The following is a description of a gene set: A protein complex that in its canonical form is composed of two identical immunoglobulin heavy chains and two identical immunoglobulin light chains, held together by disulfide bonds and sometimes complexed with additional proteins. An immunoglobulin complex may be embedded in the plasma membrane or present in the extracellular space, in mucosal areas or other tissues, or circulating in the blood or lymph. species: Mus musculus Mouse Gene Set: GOCC_IMMUNOGLOBULIN_COMPLEX, and this is the list of marker genes: Igkv12-44, Igkv14-111, Ighv3-5, Igkv7-33, Cd79a, Igkv9-120, Igkv8-30, Igkv4-90, Trav16d-dv11, Igkv3-4 (NCBI Gene Id 626347), Trdv2-2, Igkv4-72, Igkv4-53, Ighv1-61, Igkv10-96, Igkv5-45, Ighv1-62-3 (NCBI Gene Id 668549), Igkv8-26, Igkv3-2, Igkv8-28, Igkv4-61, Igkc, Ighm, Igkv3-5, Igkv6-20, Igkv8-19, Vpreb1a, Igkv5-39, Pigr, Iglc3, Igkv4-79, Cd79b, Igkv11-125, Trdv5, Igkv1-132, Jchain, Igkv13-84 (NCBI Gene Id 692152), Ighd, Trav16, Ighv1-72, Ighv1-84, Igkv6-14, Igkv4-92, Igkv17-121, Igkv10-95, Igkv2-112, Igkv6-32, Igkv4-74, Trdv4, Igkv3-7, Igkv3-1, Igha, Igkv5-48, Iglv1, Igkv4-57, Igkv1-131, Igll1, Igkv1-133, Igkv3-3, Igkv4-51, Igkv8-34, Igkv6-23, Igkv4-91, Ighg2c, Igkv2-137, Iglv3 (immunoglobulin lambda variable 3), Igkv15-103, Igkv1-122, Iglc4, Igkv8-27, Igkv4-80, Ighv2-4, Igkv2-109, Igkv4-50, Igkv4-69, Igkv4-81, Igkv4-58, Ighe, Igkv4-57-1, Igkv8-21, Igkv18-36 (immunoglobulin kappa chain variable 18-36), Igkv9-123, Igkv6-17, Ighg1, Igkv20-101-2, Syk, Igkv1-110, Igkv12-46, Iglc2, Iglc1, Igkv4-68, Igkv5-43, Ighg3, Igkv1-88, Ighg2b, Igkv16-104, Igkv8-24, Igkv4-78 (NCBI Gene Id 545849), Vpreb3 (NCBI Gene Id 22364), Igkv17-127, Lime1, Igkv9-124, Igkv12-41, Igkv4-59, Igkv3-10, Igkv6-13, Igkv4-70, Igkv6-25, Igkv8-18, Igkv1-135, Ighv3-6, Trav15n-2, Igkv10-94, Igkv1-117, Igkv6-15, Igkv13-85 (NCBI Gene Id 434036), Igkv14-126, Igkv4-55, Trdv2-1, Igkv4-63, Igkv3-12, Vpreb1b, Trav16n, Igkv3-9, Igkv5-37